The following is a description of a gene set: Reactome Pathway: Loss of proteins required for interphase microtubule organization from the centrosome In addition to recruiting proteins and complexes necessary for increased microtubule nucleation, centrosomal maturation involves the loss of proteins involved in interphase microtubule organization and centrosome cohesion. studied in species Homo sapiens part of: Centrosome maturation, and this is the list of marker genes: CEP57, CEP41, CEP290, PRKAR2B, CDK5RAP2, HAUS2, CEP131, TUBB4A, CEP72, CEP164, CPAP, CEP152, TUBA1A, HSP90AA1, CKAP5, CEP135, DCTN2, ODF2, PAFAH1B1, CEP76, CEP78, YWHAE, CLASP1, CEP250, CEP63, HAUS3 (NCBI Gene Id 79441), HAUS6, TUBA4A, NEK2, NINL, DCTN3, CETN2, NEDD1, SSNA1, DCTN1, CDK1, DYNC1H1, PRKACA, YWHAG, HAUS7, CEP43, HAUS4, CSNK1D, CEP70, ALMS1, CEP192, TUBB4B, PCM1, HAUS1 (HAUS augmin like complex subunit 1), PCNT, CSNK1E, AKAP9, CNTRL, HAUS5, TUBB, HAUS8, OFD1, PPP2R1A, DYNC1I2, MAPRE1, DYNLL1, SDCCAG8, PLK1, PLK4, CCP110, NDE1, SFI1 (SFI1 centrin binding protein), TUBG1, ACTR1A